The following is a description of a gene set: Both Retinoid-related orphan receptors (RORA, RORB, RORC) and the heme-binding nuclear receptor NR1D1 (REV-ERBA) bind ROR response elements (RREs, ROREs) in DNA. RORs and NR1D1 produce opposite effects, however: RORs recruit coactivators such as EP300 (p300) and PPARGC1A to activate transcription; NR1D1 recruits the corepressor NCOR1 and the histone deacetylase HDAC3 to repress transcription. Reactome Pathway: RORA,B,C and NR1D1 (REV-ERBA) regulate gene expression species: Homo sapiens part of: Circadian clock, and this is the list of marker genes: SREBF1, TBL1X, RXRA (NCBI Gene Id 6256), HELZ2, PPARGC1A, NCOR1, NRIP1, NCOA2, NCOA6, CHD9, CREBBP, PPARA, NCOA1, TBL1XR1, EP300 (NCBI Gene Id 2033), RORA, ELOVL3, NR1D1, TGS1, SMARCD3, MED1, RORC, CARM1, CPT1A, HDAC3